Given this list of marker genes Ttll3, Cep41, Naa20, Vkorc1l1, Ttll5, Ttll9, Ggcx, Ttll8, Ttll7, Ttll6, Agbl2, Vkorc1, Agbl3, Naa80, Ttll4, Agtpbp1 (NCBI Gene Id 76578), Tpgs1, Agbl4, Ttll10, Cfap20, Agbl1, Ttll1, Agbl5, Ttll11, here is a description of the gene set: Mouse Gene Set: GOBP_PEPTIDYL_GLUTAMIC_ACID_MODIFICATION The modification of peptidyl-glutamic acid. species: Mus musculus